The following is a description of a gene set: studied in species Homo sapiens Human Gene Set: GOMF_IGG_RECEPTOR_ACTIVITY Combining with an immunoglobulin of an IgG isotype via the Fc region, and transmitting the signal from one side of the membrane to the other to initiate a change in cell activity., and this is the list of marker genes: FCGR3A, FCGR3B, FCGR1BP, FCGR1A, FCGR2B, FCGR2A, FCGR2C